The following is a description of a gene set: Mouse Gene Set: REACTOME_MAPK_FAMILY_SIGNALING_CASCADES species: Mus musculus MAPK family signaling cascades, and this is the list of marker genes: Usp17lb, Rasgrp4, Fgf17, Rasgef1a, Fga, Fgf10, Hbegf, Camk2a, Fgfr4, Rce1, Psmd6, Rapgef2, Wdr83 (NCBI Gene Id 67836), Ptk2, Abhd17c, Camk2g, Tyk2, Cdk1, Uba52rt, Araf, Psma1, Iqgap1, Kbtbd7, Shoc2, Nrg1, Fgf8, Jak2, Psmd7, Icmt, Fgf22, Ranbp9, Gfra3, Syngap1, Csk, Dlg1, Psma2 (proteasome subunit alpha 2), Areg, Map2k1, Egf, Dusp5, Pdgfrb, Mapk3, Septin7, Kl, Kitl, Pak1, Rasa3, Psmd11, Tgfa, Psmb2, Spta1, Rgl1, Dusp1, Etv4, Fgf23, Rasgrp3, Fgf1, Foxo3 (NCBI Gene Id 97633), Ptpn7, Ppp2ca, Pdgfb, Rap1b, Map3k11 (NCBI Gene Id 76541), Sos1, Gfra4, Arl2, Pik3r2 (NCBI Gene Id 18709), Sptbn5, Psmd1, Ppp5c, Pde6d, Pspn, Sptbn2, Il3, Fgb, Mapk12, Ppp2r5c (protein phosphatase 2, regulatory subunit B', gamma), Xpo1, Ppp2r5b, Met (met proto-oncogene), Usp17ld, Nefl, Dusp16, Arrb1, Psmd13, Psmb7, Spred2, Pik3r1, Fn1, Mapkapk5, Camk2d, Ret, Ppp2r5d, Ubc, Grin1 (glutamate receptor, ionotropic, NMDA1 (zeta 1)), Calm2, Psmc4, Psmd2, Rac1, Rasgrf2, Fnta, Ereg, Fntb, Ubb, Dusp9 (dual specificity phosphatase 9), Cnksr2, Mapk1, Il2rg, Gfra2, Pea15a, Phb1, Dusp7, Hgf, Mapk6 (mitogen-activated protein kinase 6), Cdc14b, Rgl2, Fyn, Psmb1, Bcl2l1, Ppp1cb, Brap, Rps27a, Dusp2, Cdc42ep5, Psma3, Ptpra (NCBI Gene Id 19262), Vcl, Kit, Pdgfra, Abhd17a, Ppp2r1b, Psma4, Nrg3, Adrm1, Dlg3, Ptpn11, Dusp4, Mark3, Csf2, Ccnd3, Arrb2, Il6ra, Grb2, Cul3, Rasgrp1, Map2k2, Lat, Usp17le, Egfr, Klb, Kalrn, Zdhhc9, Psmb3, Gdnf, Fgf9, Paqr3, Fgf16, Frs2, Fgg, Psmd3, Psmc6, Il2ra, Dnajb1, Ppp2r5a, Irs2, Sptbn1, Psmd14, Fgf5, Fgf18, Il17rd, Lrrc7, Psmb5, Csf2rb2, Dlg4, Psma5, Il5ra, Psmc3, Sptbn4, Ywhab, Pak3, Usp17lc, Fgf3, Mras, Cdc42ep3, Actg1, Il5, Fgf20, Artn, Lamtor3, Ksr2, Erbb4 (erb-b2 receptor tyrosine kinase 4), Rgl3 (ral guanine nucleotide dissociation stimulator-like 3), Braf, Calm1, Ppp1cc, Cnksr1, Rasal1, Fgf15, Epgn, Grin2d, Tek, Il6st (NCBI Gene Id 71317), Rasal3, Rbx1, Golga7, Dusp10, Sptan1, Actn2 (actinin alpha 2), Prkaca, Nrtn, Il2rb, Fgf7, Actb, Csf2rb, Rap1a, Prkcq, Spred1, Fgfr3, Spred3, Ksr1, Rasa1, Cdc42, Shc3, Erbb2, Apbb1ip, Dab2ip, Dusp8, Ppp2r5e, Camk2b, Rasal2, Ralgds, Psmc1, Shc1, Fgf4, Psmc5 (protease (prosome, macropain) 26S subunit, ATPase 5), Rasa2, Uba52, Angpt1, Pik3ca (phosphatidylinositol-4,5-bisphosphate 3-kinase catalytic subunit alpha), Lamtor2, Itgb3, Psma6, Hspb1, Il6, Mapk4, Pik3cb (NCBI Gene Id 74769), Psmc2 (NCBI Gene Id 19181), Sptb, Flt3l, Ptpn3, Frs3, Cdc42ep2, Psmd12, Ppp2r1a, Psmd8, Pdgfa, Kras, Itga2b, Calm3 (calmodulin 3), Usp17la, Rasgrf1 (NCBI Gene Id 26449), Pak2 (NCBI Gene Id 77101), Lypla1 (NCBI Gene Id 18777), Ppp2cb, Il2, Pebp1, Psmb4, Dlg2, Erbb3, Fgfr1, Prkacb, Foxo1, Btc, Abhd17b, Rasa4, Fgf2, Src, Cdc14a, Hras, Dusp6, Raf1, Vwf, Gfra1, Tln1, Nf1, Fgf6, Shc2 (NCBI Gene Id 216148), Psma7, Psmb6